The following is a description of a gene set: Any process that stops, prevents, or reduces the frequency, rate or extent of DNA replication. studied in species Homo sapiens Human Gene Set: GOBP_NEGATIVE_REGULATION_OF_DNA_REPLICATION, and this is the list of marker genes: GMNN, FBXO5, S100A11, SLFN11, ENPP7, LIG3, CDC6, TIMELESS, CAMSAP3, TP53, CDT1, GTPBP4, BCL6 (BCL6 transcription repressor), PDS5A, TSPYL2, WAPL, TTF1, ATR, TERF1, HCRT, GDF2, RAD17, TIPIN, DYNLL1